The following is a description of a gene set: Human Gene Set: GOBP_CATECHOL_CONTAINING_COMPOUND_BIOSYNTHETIC_PROCESS The chemical reactions and pathways resulting in the formation of catechol-containing compounds. Catechol is a compound containing a pyrocatechol nucleus or substituent. species: Homo sapiens, and this is the list of marker genes: MOXD1, DBH, NR4A2, NT5DC2, ATP7A, VPS35, DAO, GPR37 (NCBI Gene Id 2861), DDC, INSM1, KL (NCBI Gene Id 9365), GATA3, SLC6A3, SNCA, TGFB2, PAH, GCH1, ALDH2 (NCBI Gene Id 217), PNMT, HDC, HAND2, MOXD2P, TH, PARK7